Given this list of marker genes RBX1, CDT1, PSMB3, SKP2, CCNE2, PSMD13, GINS1, PSMD14, PSMC6, CDK2, RFC1 (replication factor C subunit 1), POLD3, GINS3, LIG1, MCM4, ORC1 (origin recognition complex subunit 1), ORC5, PRIM2, PSMD12, PCNA, POLA1, POLE (NCBI Gene Id 80252), MCM5, CCNA1, ANAPC10, CCNE1, SKP1, CDC26, CCNA2, GINS4, PSMD6, PSMD11, PSMC2, MCM7, PSMD8, PRIM1, CDC45, ANAPC2, PSMD7, ANAPC11, RPA1, MCM2, POLD2, PSMB2, POLA2, UBE2E1, UBB, RFC2, RFC5, ANAPC5 (anaphase promoting complex subunit 5), GINS2 (NCBI Gene Id 51659), UBE2S, PSMC1, PSMD1, RPA3, ORC4, UBE2C, PSMC3, PSMA4, FEN1, MCM3, CDC16, UBC, PSMD2, PSMB7 (NCBI Gene Id 5695), PSMA7, POLD1, UBE2D1, POLE3, CDC23, GMNN, ANAPC7, PSMA1, UBA52, PSMD3, PSMB4, POLE2, ORC3, SEM1, ORC2, POLE4, PSMA6, CDC27 (cell division cycle 27), ANAPC16, RPS27A, DNA2, RPA2 (replication protein A2), PSMB1, ADRM1, RFC3, PSMC5, ANAPC1, ORC6, RFC4, POLD4, MCM6, PSMB5, PSMA5, PSMB6, PSMA2, MCM8, ANAPC4, FZR1, PSMC4, CUL1, ANAPC15, PSMA3, CDC6, here is a description of the gene set: species: Homo sapiens part of: DNA Replication; S Phase Reactome Pathway: Synthesis of DNA The actual synthesis of DNA occurs in the S phase of the cell cycle. This includes the initiation of DNA replication, when the first nucleotide of the new strand is laid down during the synthesis of the primer. The DNA replication preinitiation events begin in late M or early G1 phase.